The following is a description of a gene set: species: Homo sapiens Corneal neovascularization Human Gene Set: HP_CORNEAL_NEOVASCULARIZATION Ingrowth of new blood vessels into the cornea., and this is the list of marker genes: DDR2, GJB6, FGFR3, COL4A1, JMJD1C, GP1BB, TACSTD2, FGFR2, PAX6 (paired box 6), NGLY1, ERCC2, CYP1B1, ARVCF, GJB2, NLRP1, HIRA, SREBF1, RREB1, WT1, MBTPS2, FGF10, SEC24C, TRIM44, TBX1, UFD1, FOXC1, COMT